The following is a description of a gene set: electronically inferred by orthology from the curated human pathway This event has been computationally inferred from an event that has been demonstrated in another species.<p>The inference is based on the homology mapping from PANTHER. Briefly, reactions for which all involved PhysicalEntities (in input, output and catalyst) have a mapped orthologue/paralogue (for complexes at least 75% of components must have a mapping) are inferred to the other species. part of: Biosynthesis of DPA-derived SPMs Reactome Pathway: Biosynthesis of DPAn-6 SPMs studied in species Mus musculus, and this is the list of marker genes: Alox12, Alox15